Given this list of marker genes FKBP1B, TMEM38B, SRI, METTL21C, PRKACA (NCBI Gene Id 5566), CLIC2, FKBP1A, MIR1-1, RYR1, PDE4D, GSTM2, GSTO1, CCL3, HRC, RYR3, CALM2, CACNG1, NOL3, CAMK2D, DHRS7C, ASPH, CACNA1C, JPH3, TRDN, CHD7 (chromodomain helicase DNA binding protein 7), ATP2A2, CCR5, AKAP6, STRIT1, SLC8A1 (NCBI Gene Id 6546), JPH2 (junctophilin 2), CALM3, MIR133A1, ATP2A1, JPH1, CASQ1, ANK2 (ankyrin 2), TMEM38A, CASQ2, PLN, DMD, ZMPSTE24, MRLN, ATP1A2, JPH4, MIR93 (NCBI Gene Id 407050), SLN, CALM1, RYR2 (ryanodine receptor 2), here is a description of the gene set: Human Gene Set: GOBP_SARCOPLASMIC_RETICULUM_CALCIUM_ION_TRANSPORT species: Homo sapiens The directed movement of calcium ions (Ca2+) into, out of or within the sarcoplasmic reticulum.